The following is a description of a gene set: Sle2c1 is an NZM2410-derived lupus susceptibility locus that induces an expansion of the B1a cell compartment. B1a cells have a repertoire enriched for autoreactivity, and an expansion of this B cell subset occurs in several mouse models of lupus. Here we showed that expression of Sle2c1 enhances NZB cellular phenotypes that have been associated with autoimmune pathogenesis. A combination of genetic mapping and candidate gene analysis presents Cdkn2c, a gene encoding for cyclin kinase inhibitor p18INK4c (p18), as the top candidate gene for inducing the Slec2c1 associated expansion of B1a cells. A novel SNP in the Cdkn2c promoter is associated with a significantly reduced Cdkn2c expression in the splenic B cells and B1a cells from Sle2c1-carrying mice, which leads to defective G1 cell cycle arrest in splenic B cells and increased proliferation of Pc B1a cells. As cell cycle is differentially regulated in B1a and B2 cells, these results suggest that Cdkn2c play a critical role in B1a cell self renewal, and that its impaired expression leads to an accumulation of these cells with high autoreactive potential. species: Homo sapiens Human Gene Set: GSE23114_WT_VS_SLE2C1_MOUSE_SPLEEN_B1A_BCELL_DN from publication Xu Z, Potula HH, Vallurupalli A, Perry D, Baker H, Croker BP, Dozmorov I, Morel L (PMID 21543644) Genes down-regulated in spleen B lymphocytes: wildtype versus lupus susceptibility locus Sle2c1., and this is the list of marker genes: SNTA1, RELN, USP19, TREX1, FCHO1 (NCBI Gene Id 23149), PCOLCE, PPT2, PIM1, DDIT3, MYO1A, SIRPA, NRTN, DGCR2, CDIPT, PLCD1 (phospholipase C delta 1), H1-4, RBM38, FOXO4, TSC22D3, ALDH6A1, RPL14, PPIF, SLC29A2, ITIH4, PSD, TRAM2, MICA, PIK3IP1, TSC22D4, H2BC6, ACR, NUCB1, PLA2G4C, CIZ1 (NCBI Gene Id 25792), RPS14, FAM3A, PHKG2, KAT2A, HDGF, GPI, PIEZO1, PPARD, TXNIP, ABR, H2AC17, JUNB, STX11, MAPK3, IGLV3-25, ZNF8, TRAFD1, PPP2R5D (NCBI Gene Id 5528), LILRA2, ABCC10, ERC1, B3GALT4, CENPB, AIF1, ADA, CDH22, CNP, DNASE1L1, ITGB2, ASIC1, CDK19, PLXNA3, PCBP3, TSN, EDN2 (endothelin 2), WWOX, SPTA1, CDC25B, POLE2, IRF2BP1, GATA4, CLCN7, IDH3G, H3C10, ECI1, RGP1, CXCR4 (NCBI Gene Id 93405), CXCR6, FAM50A, FLOT2, FCER2, CTSA, CD300C, SIT1, SUN2, TBC1D9B, P2RX5, GRIK3, TTLL3, KAT7, VIPR1 (NCBI Gene Id 9357), CCNE1, NME3, DGKZ, ERICH1, CTSK, ZNF101, GGA2, PPEF2, LFNG, S100A1, PFKL, FGFR4, MVD, ZBTB25, KCTD2, RHBDL1, GLYAT, DGKA, ETV1, SERPINF1, GNB2, NCAPD2, SC5D, MYO6, MAN2B1, LPAR2 (NCBI Gene Id 9170), PTPN18, MICAL3, CIT, SIX1, TFAP4, TRAF3IP2, AREG, VAMP5, MINAR1, CHRNA4, THEMIS2, PHLDA2, UPK3A, MAPK11, DNAJB1, ALOX5, NNMT, KCNJ12, PCDH7, TFDP2, TRIB2, TCAP, SEC14L2, GDPD5, RASGRP2, CRP, SPEG, H4C2, MAP4K2, CYP3A5, H2BC10, HPGD, TMSB10, SMAGP, TBXA2R, KRTAP5-9, MAP3K3, MDK, CTSW, HGFAC, CDH3, CDX2, PYGM, ARSA, GADD45A, JAK3, ACVR2B, RPGRIP1L, NAAA, EXTL3, NAGLU, CDON (NCBI Gene Id 50937), ID1, RGS9 (regulator of G protein signaling 9), MT2A, STMN2, MAP3K9 (mitogen-activated protein kinase kinase kinase 9), KLF5, CDH2, IMPDH1, RAPSN, LHX2, PLA2G1B, WNT8B, TLR1, ACAA1, SRCAP, HSD3B2, CHD2, CD37, EN2, R3HDM1, BIN1, UBE2C, PIM2, SLC25A42, CPZ, MEGF6